The following is a description of a gene set: Genes predicted to be targets of miRBase v22 microRNA hsa-miR-548f-5p in miRDB v6.0 with MirTarget v4 prediction scores > 80 (high confidence targets). Human Gene Set: MIR548F_5P studied in species Homo sapiens from publication Chen Y, Wang X (PMID 31504780), and this is the list of marker genes: PLAC8, CBFB, HOXA9, SFRP2, AS3MT, PRSS23, TNPO1 (transportin 1), ZNF516, KLHL15, GIT2, CNKSR2, TMEM9B, IDS, NADK, ITM2C, SLC38A1, ADAMTS15, PCGF5, GDAP2, AFTPH, ATG14 (autophagy related 14), HIPK3, SLC2A13, UNC5C, CREBRF, MAT2B, FOXJ2, ARHGEF7, PCDHA12, PCDHA1, RICTOR, MIER1, MMGT1, BTBD7, RSPO3, ST8SIA3, ESR1, CACUL1, UCP3, PTPRR, ZBTB18, ARPP19, ATP11A, SYT11, EPC2, RHAG, PCDHA4, PDS5A, KCNJ13, KCTD8, CTDSPL2, PRDM16, GPM6A, SCN3A, PSAP, PGM3, MEAK7, UHRF2, PAX9, FBXO8, MED13L, CAND1, INO80D, GCC2, HSBP1, PIGK, TGFBR2, VKORC1L1, PIK3R3, TMCC3, KIAA0586, ZC3HAV1L, PPTC7, ATP6V1B2, CLINT1, MEF2C, GNPNAT1 (glucosamine-phosphate N-acetyltransferase 1), GRM7, ACYP2 (NCBI Gene Id 98), LNPEP, PRKAR2B, LRP8, TRIM33, RASGRP4, SPATA6L, SGPP1, PPM1B, TAOK1, KLHL8, PCCB, CLIP4, FSTL1, NCOA4, NHEJ1, IGF2BP2, WDR44, RBMS1, FZD6, PPP1R3B, C2orf42, SGCB, SEMA4C, RBM27, KLF10, ELAVL4 (ELAV like RNA binding protein 4), CPEB3, SLC12A8, UTS2, HOXC10, ASB5, RC3H1, POU3F4, AMMECR1, SLC4A7, TSHZ3, USP19, CCNL1, ST3GAL2, RUNX1T1, GPC3, ABCB10, CD47 (CD47 molecule), ATRN, UBA3, LRRFIP1, MGAT2, RAB21, CREB1, KBTBD8, POC1B-GALNT4, GALNT4, WNK3, SECISBP2L, FRZB, PPP3R1, SCAF11, C14orf132, ADNP, TCF4, SLC6A6, YAP1, CAMK2G, ATP11B, DICER1 (NCBI Gene Id 4333), GSPT1, TMTC1, ELOC, ATAD2B, PLEKHA1, ERF, PALD1 (NCBI Gene Id 27143), BRWD3, CSMD1, TRAPPC10, GPR85, SMAD4, C15orf61, SPTLC2, EGR4, BBOX1, KRTAP2-4, USP33, LCLAT1, ANO4, S1PR1, HNRNPR, EPB41L4A, LCOR, SRSF12, L3MBTL3, PIP5K1B, EIF2D, SMU1, GALNT16, ANKRD46, ARL6IP1, LRRC8B, FGD6, PPP1R3D, F3, NAV2, MAN1A1, BMP3, SYNM, CTNNB1, CLOCK, MAP3K20, FAM168B, RBMS2, SETDB2, INSIG1, RAB9B, IPMK, TGM3, HECW2, CHMP2B, SOX6, TENT2, ZNF708 (zinc finger protein 708), PRPF39, KDM2B, STRN, LONRF3, SELENOT, ZNF598, TRIO, PHLDB2, MED12L, DAPK1, GPBP1L1, MAPKAPK2, MAPRE2, AGPAT5, ZC3H4, USP25, CPS1, TRA2B (transformer 2 beta homolog), ACSL6, SENP2, CDK19, FBXO9, KCNE3, CBX6, PCDHA2, MBL2, DCUN1D4, PPP2R5E, ANKRD44, ENTHD1, TMEM14B, ACADL, PCDHA8, PPP1R15B, SORCS1, STXBP5, SPRED1, SPON1 (NCBI Gene Id 84806), DPP10, ADGRA2, RFX7, DPY30, ACVR2A (NCBI Gene Id 92), API5, NPTN, SEH1L, MTF1, IVNS1ABP, ZNF367, KCNJ4, TMEM255A, MYBL1, UVSSA (NCBI Gene Id 57654), SF3B3, PCDHA5, SLITRK5, IGFBP3, CDC27, NLGN4Y, THSD7A, SUPT7L, PCDHA6, LSM12, CCAR2, CYLD, CPSF6, PROX1, NEDD1, CCR2 (C-C motif chemokine receptor 2), PCDHA13, PCDHAC2, B3GNT2, AEBP2, DDX39B, SAP30L, RAB23 (RAB23, member RAS oncogene family), PDZRN3, MAMDC2, CERT1, PUM1, MFHAS1, CAMSAP1, PCDHA10, MAPK8, ELOVL5, FOXN3, MEF2A, TSC1, HMGA2, SEPTIN11, PFDN4, SLC30A5, PAK5 (p21 (RAC1) activated kinase 5), PSD3, KBTBD11, DIAPH1, ELOVL6, TGIF2, TENT4B, HOXA1, CHFR, ARPC3, SALL1, GALNT2, WBP4, NDFIP2, FRA10AC1, PCDHA7, SH3KBP1, PCDHAC1, KLF7, MATN3, CFL2, CCAR1, TMEM98, NGLY1, SHANK1, GABRA5, RHOBTB3, TPGS2, SULT1E1, ZC3H7A, PDCD10, KMT2E, TAOK3, PEX5L, CAMK2B, MPRIP, MKX, TMEM250, EPS15, MAFG, NUP58, PCDHA3, BNC2, PLXNA4, SLC30A4, NANP, MTTP, SIM2, GLS, ABLIM1, GPATCH2L, CACNA1C, JAKMIP1, GUCD1, GABRA4, FAM76B, TNFRSF19, SNX27, GID4, TLCD4-RWDD3, CNTNAP3B, MAEA, SLC16A7, RARG, CNTN1, PCSK5, RIMS2, TGFBR1, KCNJ3, ABHD17B, LONRF1, DOCK9, DLG2, SERBP1, INPP5J, CNTFR, DNAJC16, RGS4, ARMC1, PRMT8, YTHDF3, PCDHA9, CGGBP1, ATP2A2, PWWP3B, MDM4, CPNE4, PAK6-AS1, GLIS3, OLFM3, THOC3, SPART, STXBP6, IL33, ALPI (alkaline phosphatase, intestinal), CDC20B, TENM1, ZEB2, DENND4C, PIK3CA, TDRP, PCDHA11, NEUROD2, MEOX2, WDR45B, MID1, KRT24, SPTY2D1, CASP10, FAR1, RGL1, SOX11, NR2C2, CNOT4, KDM7A, ECT2, NRXN1, SMURF2, GTF2A1, LRP2, CBR4, FZD3, SACS, YES1, SNIP1, RBM11, C1QTNF2, SDC1, SDC2, NEDD4L, MAP2, BPTF, MAP2K3, RPL26L1, TP63, USF3, CLIP1, DOCK8-AS1, MSL2, SOCS6, NUP107, TXNL1, DDHD2, PRKAA1, SMCR8, ZBTB41, GABRB2, ZMAT3, RNF19A, ZNF92, EZH2, RBAK (RB associated KRAB zinc finger), FNDC3B, XYLT1, MIP, LRP6, ELAVL1, FAM217A, USP4, LYPLA1 (lysophospholipase 1), FLNC, VPS35, C11orf96, BMPR2, MSRB3, PDE5A, FAM43A, ABI1, ORMDL3, DSG1, TRIM67, ROBO1, SPTSSB, SRBD1, NKX3-1, DNA2, EIF4B, GNAI3, JCAD, MEGF10, MYL12A, MMP16, BNIP2, CABLES2, PLCB1, FAM117A, SORBS1, KPNA6, ZNF217, SENP1, LINC02693, HCFC2, CALHM4, CDC42BPA